The following is a description of a gene set: species: Homo sapiens Human Gene Set: GOBP_L_ALANINE_TRANSPORT The directed movement of L-alanine, the L-enantiomer of 2-aminopropanoic acid, into, out of or within a cell, or between cells, by means of some agent such as a transporter or pore., and this is the list of marker genes: SFXN1, SLC36A1, SLC36A4, SLC38A3, SLC38A5, SLC1A4, SLC38A4, SLC36A3, SLC3A2, SLC36A2, SLC7A8